Given this list of marker genes NDST1, HS6ST2, NDST4, HS3ST6, HS3ST5, HS3ST3A1, HS3ST2, NDST2, HS6ST3, HS3ST4 (heparan sulfate-glucosamine 3-sulfotransferase 4), HS2ST1, HS3ST3B1, HS3ST1, HS6ST1, NDST3, here is a description of the gene set: Catalysis of the reaction: 3'-phosphoadenosine 5'-phosphosulfate + heparan sulfate = adenosine 3',5'-bisphosphate + sulfated heparan sulfate. species: Homo sapiens Human Gene Set: GOMF_HEPARAN_SULFATE_SULFOTRANSFERASE_ACTIVITY